The following is a description of a gene set: from publication Gutiérrez NC, Ocio EM, de Las Rivas J, Maiso P, Delgado M, Fermiñán E, Arcos MJ, Sánchez ML, Hernández JM, San Miguel JF (PMID 17252022) The tumoral clone of Waldenström's macroglobulinemia (WM) shows a wide morphological heterogeneity, which ranges from B lymphocytes (BL) to plasma cells (PC). By means of genome-wide expression profiling we have been able to identify genes exclusively deregulated in BL and PC from WM, but with a similar expression pattern in their corresponding cell counterparts from chronic lymphocytic leukemia (CLL) and multiple myeloma (MM), as well as normal individuals. The differentially expressed genes have important functions in B-cell differentiation and oncogenesis. Thus, two of the genes downregulated in WM-BL were IL4R, which plays a relevant role in CLL B-cell survival, and BACH2, which participates in the development of class-switched PC. Interestingly, one of the upregulated genes in WM-BL was IL6. A set of four genes was able to discriminate clonal BL from WM and CLL: LEF1 (WNT/beta-catenin pathway), MARCKS, ATXN1 and FMOD. We also found deregulation of genes involved in plasma cell differentiation such as PAX5, which was overexpressed in WM-PC, and IRF4 and BLIMP1, which were underexpressed. In addition, three of the target genes activated by PAX5 - CD79, BLNK and SYK - were upregulated in WM-PC. In summary, these results indicate that both PC and BL from WM are genetically different from the MM and CLL cell counterpart. Human Gene Set: GUTIERREZ_WALDENSTROEMS_MACROGLOBULINEMIA_1_DN studied in species Homo sapiens Genes exclusively down-regulated in B lymphocytes from WM (Waldenstroem's macroblobulinemia) patients but with a similiar expression pattern in the normal cells and in the cells from CLL (chronic lymphocytic leukemia) patients., and this is the list of marker genes: S100A8 (S100 calcium binding protein A8), DUSP1, GPR183, TENT5C, FOSB, NR4A2, TNFRSF13B, IL6, HCK